The following is a description of a gene set: Reactome Pathway: PTK6 Activates STAT3 electronically inferred by orthology from the curated human pathway This event has been computationally inferred from an event that has been demonstrated in another species.<p>The inference is based on the homology mapping from PANTHER. Briefly, reactions for which all involved PhysicalEntities (in input, output and catalyst) have a mapped orthologue/paralogue (for complexes at least 75% of components must have a mapping) are inferred to the other species. part of: Signaling by PTK6 studied in species Mus musculus, and this is the list of marker genes: Socs3